The following is a description of a gene set: Cellulitis Human Gene Set: HP_CELLULITIS studied in species Homo sapiens A bacterial infection and inflammation of the skin und subcutaneous tissues., and this is the list of marker genes: ANGPT2, GJC2, SHANK3, LMNA, SLC35A1, CYBB, PLCG2, IL6R, SRP19, PIK3R1, COL1A1, SPI1, STAT3 (NCBI Gene Id 6774), IL2RA, SLC35C1, PSTPIP1, ARPC1B, AEBP1, CD79A, IGLL1, BLNK, NCF2, PIK3CA, GATA2, PIEZO1, SLC39A7 (solute carrier family 39 member 7), RAC2, TCIRG1, ELANE, NCF1, TCF3, KIF11, AGGF1, CLPB, LRRC8A, TNFRSF1A, BTK, PIK3CD, CD79B, MPEG1, GFI1, CXCR4, VEGFC, EPHB4, CYBA, RFX5, PHEX, FLT4, FOXC2, IGHM